The following is a description of a gene set: Human Gene Set: GATTGGY_NFY_Q6_01 from publication Xie X, Lu J, Kulbokas EJ, Golub TR, Mootha V, Lindblad-Toh K, Lander ES, Kellis M (PMID 15735639) species: Homo sapiens Genes having at least one occurrence of the highly conserved motif M5 GATTGGY in the regions spanning 4 kb centered on their transcription starting sites. This matches the transcription factor binding site V$NFY_Q6_01 (v7.4 TRANSFAC). Comprehensive identification of all functional elements encoded in the human genome is a fundamental need in biomedical research. Here, we present a comparative analysis of the human, mouse, rat and dog genomes to create a systematic catalogue of common regulatory motifs in promoters and 3' untranslated regions (3' UTRs). The promoter analysis yields 174 candidate motifs, including most previously known transcription-factor binding sites and 105 new motifs. The 3'-UTR analysis yields 106 motifs likely to be involved in post-transcriptional regulation. Nearly one-half are associated with microRNAs (miRNAs), leading to the discovery of many new miRNA genes and their likely target genes. Our results suggest that previous estimates of the number of human miRNA genes were low, and that miRNAs regulate at least 20% of human genes. The overall results provide a systematic view of gene regulation in the human, which will be refined as additional mammalian genomes become available., and this is the list of marker genes: ATP5MC2, UTP18, TPCN1, KIF1B, CPT1A, STMN4, ENSA, SEC11A, RUNDC3A, RGS4, CCDC85B, PLK1, INTS7, CNTROB, GPR137B, MARCHF5, SPRED2, IVD, PDLIM4, HNRNPA0, ZNF281, PROM2, MBD6, LMO4, ALDH6A1, FGD4, SARS2, OTP, GABRA1, PPP1R3C, IQCD, PDP1, DNAI3, SPC25, LINS1, ZSWIM1 (zinc finger SWIM-type containing 1), HLA-DRB1, MC4R, TCTN2, PER3, TAFA4, DPF3, CLCNKA, MTRFR, MROH8 (NCBI Gene Id 149674), TAOK3, GCA, HPD, SRSF2, PTMS, SRSF8, GLRX5, PIK3IP1, TMEM129, WARS1, OGG1, ARRDC3, PRDM5, CLEC18C, IRS1, PDE6D, MCM8, TNRC6C, SEPTIN4, NEUROG1, PHF5A, L3MBTL2, CYP4F8, RBM4B, MYH14, RHOQ, STARD7, RNF181, VCP, PIP5K1A, JARID2, CCNA1, RBM48, G3BP2, RPLP1, SNRPD2, PPP2R5A, LUC7L2, DHX57, AURKA, ABHD15, COPS4, ASB7, ETF1, TECR, HNRNPUL1, R3HDML, ALDH4A1, SIK3, TCERG1, TMEM184C, USP2, SOX4, ELAC2, RHOF, DSTN, COX6A2, SARNP, PRKDC, H3-3B, CDH10, USB1, MID1, BCAT2, SMIM29, NTRK1, TAS1R1, TMEM183A, ERCC1, KLHL25, TFPT, NT5DC2, RNF148, MAZ, MOSPD3, SSX3, HNRNPH2, PPM1D, ANO4, ATP10D, CYLD, BTBD3, PIGA, HMG20B, CDK2AP2, PPP2R5E, WBP1, WNT3, WDR81, UPF2, GABRQ, LYRM7, HOXB6, ZFAND2A, EIF4E, BARHL1, HOXC4, BIVM, QTRT2, NCEH1, SLC25A35, GRIA3, YARS1, NUMB (NUMB endocytic adaptor protein), PARD6A, COA3, RAB5IF, PSMD4, DUSP10, IRX3, ZNF436, ELP4, ZNF189, CBFA2T2, WTAP, FAM120A (family with sequence similarity 120 member A), ABCF2, INHA, CACNA1E, CYTH2, CIART, CPEB4, SESN3, PITX3, AGPAT1, COL1A1, H3C7, ELAVL3, ZIC5, NRGN, FUCA1, DLD, SIX1, CDR2L, TIAM1, MCM4, NR2C2, MACO1, IST1, FGGY, ZNF597, OTUD5, CASP2, AAMP, PRKD2, RNF26, H2AC25, H1-3 (H1.3 linker histone, cluster member), MLF2, BAG4, SPCS2, PCNT, BMAL1, MTERF2, KATNAL2, CLSPN, NLK, MRPL50, KPNB1, IRF6, CYP4F2, IER5, CLTA, SACM1L, DDX10, NKX6-2, MAP3K3, OARD1, SSX5, PRMT5, NHERF1, SNX11, RAP2B (NCBI Gene Id 5912), RAB11B, RNF40, DAXX, PRADC1, SLC39A9, CSTF1, RNFT2, SLC26A9, GNGT2, GRAMD2B, SF1, PRR11, ATP5MK, MMD (monocyte to macrophage differentiation associated), PIK3R1, UBP1, PIAS4, DMRT2, SSBP3, CHODL, MSX1, AMER1, AP4M1, HAPSTR1, CCT3, GPR85, CCDC186, SC5D, MRPS12, NRDC, RAG1, H2AC21, PDK2, MSRB1, CYP26B1, KIF20A, NDST4, H2AX, RAB6A (RAB6A, member RAS oncogene family), SHC3, ADAMTS19, BDNF, DLX1, PTK2B, NSDHL (NCBI Gene Id 50814), CCT7, DENND4A, MAPK7, SRSF6, CIRBP, CELSR3, TLE4, TFCP2, RAB5B, MIPOL1, XRCC3, HIGD1A, HOMEZ, EAF2, TOP2A, TAC3, EGLN3, RPS6KA5, MTOR, TTN, MOB1A, UBE2F, SKAP2, HOATZ, BRCA1, HSPA1L, B2M, FASTK, UBE2C, SYCP3, H2BC26, AASDHPPT, SFRP5, EHMT2, RECQL5, BORA, TNPO2, DNAJB11, RPA2, NOL4, ZC2HC1C, JUNB, NDE1, BCL2L1, PITPNM1, ZNHIT3, ARL3, AKIRIN2, TREX1, TGIF1, H2AC6, ZBED5, SUZ12, ACR, PBX1, GORAB, RBM10, UACA, AGAP3, MSL3, LTV1 (LTV1 ribosome biogenesis factor), DDX4, HSCB, KDM4D, MECP2, H1-6, EFNA5, GTPBP2, C9orf85, KLHL4, SAP30BP, ARHGAP26, RAVER1, PCYT2, STIM1, NKX3-1, FKBP3, TSC22D1, H3C1, H4C1, PLA2G6, TMEM94, PRPF38B, ZFP91, USP21, GABRR2, THBS2, TSACC, ADAMTSL1, PARPBP, PNKD, CGRRF1, MTMR14, TENT5B, STMN2, CYP39A1, ZFHX4 (NCBI Gene Id 79776), MYOCD, LRP8, LHX1, ZNF362, NF2, UFD1, BRD8, C12orf57, ABAT, LGALSL, HTN1, PSRC1, NANS, BCL9, HSPA5, MPHOSPH8, MAEL, SFRP1, KLC4, SGO2, INHBE, ZNF385A, STAG1, HMBS, COQ10B, DCUN1D4, PCBP1, CALU, WNT8B, AP2A1, TMEM143, RHOB, CALHM1, UBE2D3, AMELX, TMEM256, ASF1B, COLQ, AMBN, CREBRF, IL11RA, CCDC102A, ORMDL2, SLC41A1, CHFR, HLA-DOA, CCNG2, CNOT3, HMGN2, ANKRD49, AKAP9, ABTB2 (ankyrin repeat and BTB domain containing 2), TESK2 (NCBI Gene Id 96574), GLA (galactosidase alpha), RIMS2, CDC14B, SKA2, CEP70, MTMR4, OGDH, DNAJB1, HMGB2, ICAM4, ACTL6A, ARPC5, PDIA3, GLRA3, DOCK9, LMOD1, ORC6, SLC9C2, COL5A3, NUP98, MEN1, HOXC11, SPAG7, IMMP1L, CUTA, REC8, CRABP2, CADM2, SORT1, PPM1B, COQ7, SIX2, P2RX6, OSBPL3, LRRIQ1, LAMP2, ERG, HDAC1, POGLUT2, OSM, IGF2BP1, HMGCS1, LRRC20, HSD11B1, PHPT1, HSP90B1, CATSPER2, ST8SIA4, CDK1, ST7, TDO2, HMGA1, NR1D1, ATF4, ENTPD7 (NCBI Gene Id 57089), VWA3B, SLC26A6, MRE11, RNASEH2A, PRCP, HLA-DRB5, GCHFR, BAHD1, SLC39A4, CDK16 (cyclin dependent kinase 16), GPX3, ADAMTS15, CNNM2, CR2, H3C8, RTRAF, GGCT, CCDC89, HTR2C, DDOST, POU3F3 (NCBI Gene Id 92240), PDCD4, KCNIP2, DDIT3, SP8 (Sp8 transcription factor), FADS1, SEL1L, HBB, CGGBP1, EPHA7, RMI1, PIM2, VLDLR, ZSWIM3, DDC, BCKDHB, YJU2B, TCTA, MRPL2, CHAC1, CDKN3, CTF1, HOXB13, ZNF436-AS1, MED21, CDC25C, TXLNG, C21orf58, DCX, CEP164, EIF4G2, TAF15, OAT, SP1, ZNF385B, FDFT1, DDIAS, TWIST1, GGNBP2, WBP2, SOX2 (NCBI Gene Id 6657), DPYSL5, SLC11A2, TAF6L, E2F8, ELOVL5, SPTB, LRP2BP, PRND, FGF4, H2BC21, PAK3, C12orf75, PLN, ANXA6, PCF11, RPRD2, RPAIN, BUB1 (NCBI Gene Id 699), RTN4IP1, NCAPH (NCBI Gene Id 679), TDRKH, LCOR, TRIB1, HOXB9, RHOA, SFXN2, OSBPL9, RASA4, OSBP, H2AC1, MAML1, PDGFRB, CCDC191, PPP2R5D, UBALD2, CEP20, G3BP1, FAM110A, DOLPP1, KBTBD3, SIGMAR1, MVD (NCBI Gene Id 4597, mevalonate diphosphate decarboxylase), TUBA1C, GSK3B, IFT122, LSM1, MRPL51, LRCH4, DDX50, IVNS1ABP, HIF1A, MYCBP2, PEX1 (peroxisomal biogenesis factor 1), KCNN2, SFXN5, NEUROD2, LANCL1, MAB21L2, COX14, PLA2G3 (NCBI Gene Id 50487), RACGAP1, LY75, AMTN, CETN2, ACTMAP, H1-5, STIP1, ZBTB20, CORO7, AKAP8, TANK, MBNL1, DLEU2, WASHC3, SPDYA (speedy/RINGO cell cycle regulator family member A), PXMP4, RGS3, NUBP2, GOT1, MTFR1, SMAD6, ANKRD12, KMT2E, MN1, AP3M2, SLC16A11, MIR22HG, NFATC4, SLC43A2, CNTD1, CIRBP-AS1, ZBTB3, VSX2, ACTR1B, EIF4EBP2, LLGL2, ETV5, ATP5MC1, TUG1, EHF (ETS homologous factor), QPCTL, PRDM10, SMAD2, RPP30, HSPA1A, ZFAND4, POLA1, ZBTB10, PAX8, HMX1 (NCBI Gene Id 3166), CCNYL1, TIGAR, PCNX1, MBNL2, CIT, SLC25A28, SIX6, EIF2AK3, IL4, SPTLC2, ABHD17B, PHF20, BMP4, DLEU1, NFYA, STMN1, TPP2, ACTL6B, MLH1, NUP88, PIGS, RBM14, PSME3, RPS9, ATOSB, DHX38, FAM117A, KPNA4, ERH, CDH9, BTG4, FBXL8, TSPAN3, SLC25A17, INVS, TNFSF11, STARD4, FTH1 (NCBI Gene Id 92182), ORC4, SERTAD1, RNF121, PANK2, WEE1, SUV39H1, SH3D21, NUDT2, LRFN4, SORBS2 (sorbin and SH3 domain containing 2), CREB5, CWC15, DBP (D-box binding PAR bZIP transcription factor), DNAJB5, NPAT, NCAPD2, GNRH2, ATOH1, LIX1L, CLDN5, CACNA1B, RLIM, BORCS6, OPA3, KDM4A, PMEL, ANAPC5, XBP1, EMX2, ARHGEF7, DNAAF6, PRUNE2, FUT8, CCDC12, ATF2, YIPF3, CCDC25, FKBP5, STAG2 (STAG2 cohesin complex component), SYNPR, RNF6, DMXL1, HOXC6, RAB4B, ESPL1, PEX2, CKS1B, FAM72A, PI4K2A, CENPQ, OS9, VPS35, RNF44, MBD4, STAT3, CSE1L, COPZ1, RPN2, CYP1B1-AS1, TMEM108, IL1RAPL1, KATNB1, TUBA1A, OR2L13, GPC3, HNRNPR, MTR, TERF1, PPIP5K1, SLC30A6, NANOS1 (NCBI Gene Id 340719), IMP4, GAN (NCBI Gene Id 8139), TAL1, CEP57, CASKIN2, POLR3F, ZBTB26, IER5L, ARAP1, FGF12, HSD17B8, DHCR24, GTF2I, TRAF7, RMI2, ZFAND6, CDH3, HIVEP3, AKR1B1, SGIP1, PABPN1, CNTN4, CPEB3, SPRING1, H2BC1, PPP2R1A, CBX5, DPYSL2, AVPI1, H2BC4, CCDC140, PRRC2A, SERTAD3, ELL2, GLS, STRA8, STIMATE, EPM2AIP1, RNF17, OSBPL6, ZNF711, LRRN1, ABI3, CD40, PIGN, R3HDM1, TACC3, TLE1, QRSL1, C1orf105 (NCBI Gene Id 92346), HLA-DOB, MAP3K13, HOXB2, MUCL1, SLC7A11, TAF8, ICAM5, FZD8, ARFGAP2, CDK5R2, TBX3, RBPJ, DCAF11, NDUFS8, EBF1, POLR2I, CCDC32, MAP2K3, SMIM12, DBI, ARL17A, RAB8B, ARRB2, ACOT8, TEPSIN, C1QTNF6, STC1, M6PR, NUP37, PYCR2, FOXN3, GPCPD1, NAV2, MRTFA, UHRF1, CDKL2, MMUT, FAM162A, SOX9, PPIL1, FAM76B, DDR2, C5orf22, ADRB1, DGKZ, CISH, RP2, PIMREG, HSD17B12, EPC2, RWDD2A, ZNF775 (NCBI Gene Id 285971), SPRYD3, LDB2, TBCC, AEN, ELAVL4, TUBB2B, PATL1, HNRNPK, TLL2, HELB, CDH6, RAB1A, NUP62CL, SFR1, NEUROG3, MINK1, NDUFAF3, USP1, PRKACA (NCBI Gene Id 5566), MCCC1, LRRN3, UBB, KIF5B, WASF2, TES, SP2, H2BC9, ASB9, RORC, TMC3, RPL14, PLIN3, CYP4F12, IFT27, ADARB2, GRHL3, RBM4, PASK (PAS domain containing serine/threonine kinase), KMT5A, NFYC, C1orf116, PPP2R5C, ZMYM2, ZIM2, YPEL5, CENPF, GALT, HOXA7, H1-1, TENM3-AS1, CCNG1, FAM32A, SUMO1, CDK19, MSH2, MRFAP1, IFI6, TMA7, COPS3, PAF1, SON, VAMP1, CHP1, MAEA, ATM, H3-4, SSR4, PAN2, MCM7, GANAB, HSPA1B, PLEKHH3, KLF1, RMND5A, CHRM1, DYNC1H1, ST8SIA1, USP39, ARHGAP11A, PPP1R7, PITX2, DLG3, NRK, FDXR, HLA-F, RGL1, CHCHD3, GMPPB, LINC01567, C3orf18, GPR50, TUT1, ACTR1A, PEG3, NPTX2, ZKSCAN5, SUCO, GINS4, GTPBP1, MTFP1, FDPS, GOLPH3L, NARF, PIK3R3, WDR47, KHSRP, HNRNPA1, IDH3G, KCNJ2, TRADD, BCAS3, IARS1, TM9SF3, MYO1E, ZDHHC5, RPH3A, SLC46A3, FXR2, ARRDC4, DGCR8, PDK4, MSX2, INSRR, TGFBR2, ETV4, SLC25A27, NPHP4, PRKCZ, GTF2A1L, ARL6IP6 (NCBI Gene Id 151188), CAT, ACTB, SH3BGR, RSPRY1, DLX3, NOP56, INSIG1, NUFIP2, ADHFE1, SAMTOR, ELMO1, TMEM25, FGFR2, TBR1, ZBTB22, ING5, CAND1, MSTN, HLA-DMA, MARCKS, ENAM, FAM120AOS, ABHD12, NCAM1, TSPAN31, NXPE3, HMGA2, HSD17B10, TSPYL2, KCNJ13, ITPR2, ANKRD11, SHH, CADM1 (cell adhesion molecule 1), PTF1A, MIS12, TP53INP2, ACYP1, CHMP2B, TP53I13, TMEM8B, PCDH17 (protocadherin 17), EIF2B2, ERRFI1, PSME3IP1 (proteasome activator subunit 3 interacting protein 1), TFR2, ALDOB, CDC45, TBCB, SAP130, AGFG2, PEX16, GRHL2, CNOT1, BICD2, CKS2 (CDC28 protein kinase regulatory subunit 2), ERG28, CAST, TRMT6, RUNX1, CDV3, NYX, PCDH9, CPNE1, TYSND1, SLC25A19, TMEM241, DZANK1, SHC1, PGK2, TRAPPC1, DALRD3, PBX3, SESN2, BPGM, NEB, PAK4, SUFU, NPTN, TXNIP, TXNL4B, FNBP4, GUCA2A, MYH8, H2BC10, HLA-DQB2, CNN3, CDC25A, SIX5, ZMAT4, CRKL, YWHAZ, CACNA1A, MORN2, UPK3A, CEP41, KLF9, SMAP2, PLCXD2, STAT2, MIR17HG, CCDC51, EZHIP, KBTBD8, DLX4, HK2, USP32, FBXO24, LIX1, SYNGR4, THRSP, ACO2, SALL1, TERB2, GART, RANBP9, STEAP2, BAG6, SLC4A7, IFFO1, PTCH1, GPR15, BRIP1, ZMYND8 (NCBI Gene Id 55497), ZEB2, ANK3, FGF11, STX16, GNAI2, RFX5, PGM3, NASP, TRIM35, TPX2, PAX6, LTBP1, NBR2, JAKMIP1, IBSP, H2AC20, ABCA7, NOL9, CCDC115, IQCB1, SNCA, FOSB, ATP1B1 (ATPase Na+/K+ transporting subunit beta 1), PRPF31, ARX, ASCL2, CETN3, MAB21L1, PRDM8 (NCBI Gene Id 56978), CDK18, TEF, EXPH5, CDH1, MRPS30, TM7SF2, TSPAN13, FICD, VAX1, C1orf87, ING2, LMAN2L, SIAH3, DROSHA (drosha ribonuclease III), DSPP, ZBTB5, ARID4A, KIF23, ELAVL2, RNF5, ZFYVE21, EXD1, NUP93, PAX3, TTC9C, TROAP (NCBI Gene Id 10024), GBF1, GPHN, CALM2, PCDH10, ZIC3, MAPK1, DLX2 (NCBI Gene Id 1746), SNRPA, TALDO1, INSM1, SLC8A3, ID4, AMELY, ZFP3, KCNA1, H1-2, MEIS1, HCP5